Given this list of marker genes Pten, Olig1, Mecp2, Eif2b1, Ulk4, B4galt6, Nsun5, Cntnap2, Mios, Clu, Ascl1, Lpar1, Fa2h, Ccdc39, Omg, Eif2b5, Tgfb1, 9630013A20Rik, Mal, Cntn1, Prdm8, Tlr2, Enpp1, Tppp, Mobp, Fgfr3, Mag, Gpm6b, Ckap5, Tenm4, Shh, Nkx2-2, Zfp488, Aspa, Eif2b3, Lyn, Tcf7l2, Id2, Ncstn, Gstp1, Cntn2, Eif2b2, Nkx6-2 (NCBI Gene Id 14912), Sox11, Med12, Myrf, B4galt5, Cntnap1, Hes5, Kcnj10, Sox10, Ercc2, Abca2, Hdac11, Wasf3, Plp1, Id4, Eif2b4, here is a description of the gene set: The process aimed at the progression of an oligodendrocyte over time, from initial commitment of the cell to a specific fate, to the fully functional differentiated cell. An oligodendrocyte is a type of glial cell involved in myelinating the axons in the central nervous system. Mouse Gene Set: GOBP_OLIGODENDROCYTE_DEVELOPMENT species: Mus musculus